The following is a description of a gene set: Genes in the cancer module 67. studied in species Homo sapiens Human Gene Set: MODULE_67, and this is the list of marker genes: ARMC2, AKAP9, FBXO4, KCNJ16, LMAN1L, BMX, ELL2, PARP9, STAC, ZKSCAN7, SYCP1, MAP4K1, UVSSA, FAU, SPZ1, SMG1, FKBPL, RGP1, ZNF431, ZNF652, KIF26B, COPS4, CYP2C9, POLI, PARD6A, ZNF112, NRXN2, MXD3, CTNNAL1, ACAP3, PYCR3, ANKRD11 (NCBI Gene Id 92821), GIPC2, SPPL3, VPS13D, JCAD, GFOD3P, ZNF107, ELMOD1, KREMEN1, RUNX1T1, MALL, NRXN1, TRAF3IP3, FBXL12, KLHL4, RSRC1, CCDC7, KMT5AP1 (KMT5A pseudogene 1), SYAP1, SNAP91, TTF1, ULK4, SGCD, NEK1, BIN2, ZNF273, HEATR3, LINC00520, CARD18, PPP1R17, PPP2R2D, ERVMER34-1, HERC5, DENND1B (NCBI Gene Id 54530), MOCS3 (molybdenum cofactor synthesis 3), TRPM1, LRRC3, DACT1, SIRPG, MAGEL2, OLIG2, DYNC1I2, PDZD2, POGLUT2 (protein O-glucosyltransferase 2), TTC29, ARAP2, WHAMM, RPRM, TEKT3, NTN4 (netrin 4), EYA4, KYAT1, ADAMTS12, QTRT1, TFPI, ZNF137P, HDDC2, RAC3, SH3BP1, IQCH, ACBD6, ACVR2A, SPTBN4, ZNF318, ZNF385D, USP24, NOL4L, GAS8, GPN1, NR2E1, TIMM13, ZFPM2, CFAP92, FJX1, ZNF638 (zinc finger protein 638), NTF3, SSH1, HAO1, AP5B1, CPNE4, RRP15, NIPSNAP3A, HOXB6, ABTB2, FBXL4, UBA6, LRP1B, ELAC1, OGFOD3, PCSK5, BUB1, CA10, NOL9, TRIM62 (NCBI Gene Id 55223), RAB11FIP1, MED23, ZRSR2P1, PAPOLG, EXO1, UACA, CHRFAM7A, PDGFD, AOX2P, RGS18, ETV5, ZMYND15, ROPN1 (rhophilin associated tail protein 1), RAB9B, POLR2L, ZMYM6, DNAH11, ANG, EDDM3B, KIAA1210, RHOU, FBXO27, VRK1, ZNF667, CRCT1, ZSCAN31, ARID1B, HAND2, IFT80 (intraflagellar transport 80), CITED4, CCDC88C, FAM181A, CSPG5, SPTA1, PADI2, PCDHA9, TAT, LINC00112, FLRT2, PPP2R3A, GTPBP6, EGFL8, INIP, ILRUN, PEX5L, GK2, PUS1, NDUFAF5, SOX21 (SRY-box transcription factor 21), AK3, VANGL1, KLF1, CLEC1B, BSPRY, BVES, NOL8, SCYL2, GRIA4, BBS7, ERVW-1 (endogenous retrovirus group W member 1, envelope), RXYLT1, CARD9, COX4I1, ZFP14, TMEM140, KRBOX1, SQLE, RND2, HSDL2, MLANA, CES3, ADAM3A, CDC27, RPS13, ZC2HC1C, DRC7, TMEM241, EFCAB6, NMNAT2 (nicotinamide nucleotide adenylyltransferase 2), DROSHA, RLN1, FGFBP2, MAP3K21 (mitogen-activated protein kinase kinase kinase 21), HYDIN, APOO, RAVER1, PXMP2, ZBTB32, USP9Y, SLAMF9, FBXO42, KCNK4, ZNF483, CNNM3, TF, KCND1, PPFIA1, PLEKHG4, BTRC, ZNF471, FAM50B, DARS2